Given this list of marker genes SLC24A4, here is a description of the gene set: The five members of the NCKX (SLC24) family are all able to exchange one Ca2+ and one K+ for four Na+. SLC24A4 encodes an exchanger protein NCKX4 which may play a role in calcium transport during amelogenesis (the process of formation of tooth enamel). SLC24A4 is upregulated in ameloblasts during the maturation stage of amelogenesis. Defects in SLC24A4 can cause hypomineralised amelogenesis imperfecta (AI), an autosomal recessive disorder in which tooth enamel formation fails. Screening of AI families identified mutations which severely diminish or abolish transport function of SLC24A4.<br><br>Genetic variants in SLC24A4 define the skin/hair/eye pigmentation variation locus 6 (SHEP6; MIM:210750). In a genomewide association scan of thousands of Icelanders and Dutch, Sulem et al. found a strong association between the T allele of a SNP in the SLC24A4 gene and blond versus brown hair and blue versus green eyes. Reactome Pathway: Defective SLC24A4 causes hypomineralized amelogenesis imperfecta (AI) studied in species Homo sapiens part of: SLC transporter disorders